Given this list of marker genes TFRC, CAMKK2, VASP, SLCO3A1, EXOC3L4, ZMYND15, CXCL3, FYB1, TNF, MIF, MYD88, SDC1, SERPINB8, HDDC2, CHCHD2, TLL1, GCM1, SLC16A10, PTGER4 (prostaglandin E receptor 4), CAMK2D, GLB1, CPD, TOMM70, PILRB (paired immunoglobin like type 2 receptor beta), ST18, STX11, PSMD10, FBRSL1, CD47, PID1, SPI1, NADK, IRAK3, GLRX, MLLT6, MAP3K8, ANXA1, GABRG3, CASP4, RELB, FSHB, RASSF4, TNFAIP2, S100A6, CTSH, TNFAIP1, ARCN1, AOAH (NCBI Gene Id 313), TRAPPC2, ARL6, JUNB, HSPA1B, IGSF6, CLEC4A, NFKBIZ, RAB20, GDPD1, LIMD1, CA13, MTMR14, ACOD1, CCDC115, CD72, POU2F2, TNFRSF11A, NEK11, ARHGDIB, CD302, RBPJ, UBE2F, PIM2, HCK, SYN1, GSAP, PDE2A, FDPS, RAPGEF5 (NCBI Gene Id 9771), EBI3, SQLE, MCL1, LARS2 (leucyl-tRNA synthetase 2, mitochondrial), GSDMA, MPZL2, POTEH, PDLIM5, CTSZ, PRXL2B, CLMP, PSMA8, EHD1, SMPDL3B, CD74, KCNN4, PTPN6, ICAM1, ZMIZ2, BCAT2, IKBKE, CIB1, IFNAR1, C3, RAD23B, MARCO, BORCS7, RNF19B, PTPRJ, ACP2, POLR2H, RAB1B, ITGAM, CCDC103, FPR2, ZNF385A, MMP14, LCP2, HDAC1, CCL5, DYNLT2B, PDE4B, NFKB1, PSMA3, IL2RG, SWAP70, MMP12, LYN, TNFSF9, EDAR, RALGDS, TMEM205, TMEM208, CFAP90, BOLA3 (bolA family member 3), MYO10, S100A4, GPR18, SLC6A12, HNMT, PLA2G7, ABTB3, NFKBIA, CAV1 (caveolin 1), N4BP1, AK4, KCNMA1, TMEM176A, CMTM8, COL18A1, ZC3H12C, TGFB1, ANKRD13B, ALAS1, TLR2, GTPBP4, CHSY3, DPH6, TANK, IFT57 (intraflagellar transport 57), KCNAB1, NUDT7, PIK3R5, FPR1, SLAMF9, FGD3, GNA15, ADGRL2 (adhesion G protein-coupled receptor L2), PFKFB3, PILRA, MOB1A, TNFAIP3, MRPL52, DOCK7, PAK1, AKR1B15, ISCU, CA5B, SYNPO, SOD2, ZC3H12A, NDUFAF1, FUS, MARCKSL1 (NCBI Gene Id 65108), NCF4, TNIP1, SLC31A2, PDE4DIP, DIAPH2, XYLT2, SRSF3, MTX2, ABCF3 (ATP binding cassette subfamily F member 3), GPR84, NKRF, NFKBIE, SLC11A2, MVD, NUPR1, RNF121, PPP1R3A, SLC25A10, RILPL2, here is a description of the gene set: Human Gene Set: GSE17301_CTRL_VS_48H_ACD3_ACD28_STIM_CD8_TCELL_DN from publication Hervas-Stubbs S, Riezu-Boj JI, Gonzalez I, Mancheño U, Dubrot J, Azpilicueta A, Gabari I, Palazon A, Aranguren A, Ruiz J, Prieto J, Larrea E, Melero I (PMID 21108462) Genes down-regulated in CD8 T lymphocytes: control versus activated by anti-CD3 and anti-CD28. studied in species Homo sapiens IFN alpha mediated gene expression pattern. The effect of IFN alpha on human CD8 T cells responding to antigen (signal 1) and costimulatory signals (signal 2) provided by beads coated with anti-CD3 and anti-CD28 mAbs. This analysis examined the effects of IFN alpha on human CD8 T cells responding to antigen (signal 1) and costimulatory signals (signal 2) provided by beads coated with anti-CD3 and anti-CD28 mAbs. Magnetically sorted untouched CD8+CD45R0- T cells from three different donors were unstimulated or stimulated with IFNa2b or with anti-CD3/CD28 Beads alone or along with IFNa2b or IFNa5 for 48 hours. Individual mRNA samples were analyzed using HG-U133A 2.0 array gene chips.